The following is a description of a gene set: The process in which the branching structure of the mammary gland duct is generated and organized. The mammary gland is a large compound sebaceous gland that in female mammals is modified to secrete milk. studied in species Homo sapiens Human Gene Set: GOBP_BRANCHING_INVOLVED_IN_MAMMARY_GLAND_DUCT_MORPHOGENESIS, and this is the list of marker genes: CSF1, DDR1, WNT5A, CSMD1, WNT4, CCL11, TFAP2C, BTRC, ESR1, MSX2, TGFB1, AREG, PGR, AR, VDR, PML, MED1, ETV5, SRC, EPHA2, PHB2, TBX3, LRP5, CAV3, KDM5B